The following is a description of a gene set: Small forehead Human Gene Set: HP_SMALL_FOREHEAD The presence of a forehead that is abnormally small. species: Homo sapiens, and this is the list of marker genes: NGLY1, CDK5, TFAP2A, INTS11, SNX14, DMXL2, KDM5C, BCKDK, MAB21L1, IFT57, NAA20, NDE1, KATNB1, PIGN, ATP6V1E1, RELN